The following is a description of a gene set: species: Homo sapiens Human Gene Set: MIR4529_3P from publication Chen Y, Wang X (PMID 31504780) Genes predicted to be targets of miRBase v22 microRNA hsa-miR-4529-3p in miRDB v6.0 with MirTarget v4 prediction scores > 80 (high confidence targets)., and this is the list of marker genes: ZBTB21, GALC, KCNT2, BEND4, RAP1B, CDKL3, PIK3CA, ITPR1, IL17RD, KCNK10 (NCBI Gene Id 54430), C9, PALMD, CCL16, KCNK15, PLB1, ANTXR1, PPM1E, RFTN2, LIX1, CLCN4, EN2, PDCD6IP, MBD5, BNIP2, UGDH, ZSCAN16, MFSD4A, ONECUT1, OPRM1, DAAM1, RAB2B, TSR1, CYP11B1, ANKRD34B, RB1 (RB transcriptional corepressor 1), CHST3, WDR20, USP9Y, HLF, FSTL5, PDZRN3 (NCBI Gene Id 23024), DCAF4L2, PRPF18, KCNJ3, TBKBP1, PHF21A